Given this list of marker genes NDUFB3, PABPN1, KY, HNRNPA1, CRYAB, RYR3, SMPX, MYPN, TNNT1, UNC45B (unc-45 myosin chaperone B), ORAI1, MYH7, TPM3, NEFL, STIM1, MYH2 (myosin heavy chain 2, NCBI Gene Id 4620), GMPPB, KBTBD13, MB, KLHL40, FHL1, MYO18B, NEB, KLHL41, LMOD3, CASQ1, COX11, DPAGT1, GYG1, ALG14, ACTA1, MYOT, RYR1, ALG2, CFL2, ADSS1, FLNC, PYROXD1, TPM2, GFPT1, GNE, here is a description of the gene set: Human Gene Set: HP_MUSCLE_FIBER_INCLUSION_BODIES species: Homo sapiens Muscle fiber inclusion bodies